Given this list of marker genes ADCY8, STAR, ADCY4, MC2R, PBX1, CREB1, ADCY9, CREB3L2, CREB3, CYP11B1, CREB3L4, PRKACB, PRKACG, ADCY2, NR5A1, SP1, CREB5, POMC, ATF4, NR4A1, ATF2, ADCY1, ADCY5, ADCY3, MRAP, CREB3L3, CREB3L1 (cAMP responsive element binding protein 3 like 1), ADCY7, ADCY6, ATF6B, GNAS, PRKACA, here is a description of the gene set: species: Homo sapiens ACTH-cortisol signaling pathway. Pathway ID: N00297. Pathway type: Reference. Pathway class: nt06310 CRH-ACTH-cortisol signaling. Human Gene Set: KEGG_MEDICUS_REFERENCE_ACTH_CORTISOL_SIGNALING_PATHWAY Pathway Definition from KEGG: ACTH -> (MC2R+MRAP) -> GNAS -> ADCY -> cAMP -> PKA -> (NR5A1,NR4A1,SP1,PBX1,CREB) => (STAR,CYP11B1) -> Cortisol